Given this list of marker genes Sh3gl3, Fcho2, Ldlrap1, Cops7b, Lrp2, Grb2, Tor1a, Cops4, Eps15, Sh3gl1, Stam2, Reps1, Tgfa, Slc2a8, Avp, Btc, Uba52, Nedd8, Arrb1, Agtr1a, Ubb, Epgn, Rps27a, Reps2, Clta, Ap2b1, Stam, Snap91, Trf, Scarb2, Dvl2, Apob, Cltb, Itsn1, Tfrc, Sh3gl2 (SH3-domain GRB2-like 2, NCBI Gene Id 319329), Igf2r, Ubqln1, Syt9, Cd4, Aak1, Cops5, Syt11, Necap1, Grk3, Cbl, Hgs, Cops3, Vamp4, Sh3kbp1, Slc18a3, Cops2, Egf, Syt8, Tor1b, Picalm, Gps1, Ston2, Adrb2, Cltc, Hbegf, Wnt5a, Itsn2, Il7r, Ubc, Ston1, Ap2m1, Vamp8, Areg, Cops6, Ldlr, Tgoln1, Epn2, Fzd4, Cftr, Uba52rt, Cops8, Cd3g, M6pr, Dab2, Eps15l1, Ap2a2, Arrb2, Epn1, Cd3d, Egfr, D130043K22Rik, Vamp3, Ereg, Vamp2, Grk2, Avpr2, Cops7a, Syt1, Ubqln2, Tacr1, Ap2a1, Necap2, Syt2, Chrm2, Ap2s1, Fcho1, here is a description of the gene set: species: Mus musculus Mouse Gene Set: REACTOME_CARGO_RECOGNITION_FOR_CLATHRIN_MEDIATED_ENDOCYTOSIS Cargo recognition for clathrin-mediated endocytosis